The following is a description of a gene set: Genes down-regulated in comparison of macrophages cultured with M-CSF versus macrophages cultured with M-CSF, IFNG and Pam3Cyc. species: Homo sapiens Gene expression analysis of freshly isolated CD14+ human monocytes and monocytes cultured in the presence or absence of interferon (IFN) -gamma for 24 h and then stimulated with Pam3Cys, a Toll-like receptor (TLR) 2 ligand, for 6 h. Results provide insight into mechanisms by which IFN-gamma reprograms early macrophage differentiation and subsequent response to TLR ligands. from publication Hu X, Chung AY, Wu I, Foldi J, Chen J, Ji JD, Tateya T, Kang YJ, Han J, Gessler M, Kageyama R, Ivashkiv LB (PMID 18976936) Human Gene Set: GSE11864_CSF1_VS_CSF1_IFNG_PAM3CYS_IN_MAC_DN, and this is the list of marker genes: VWA7, TBC1D1, ZSWIM8, MICA, PLEKHG1, YKT6, PNPLA5, MAP1S, COQ7, BNIP1, FEZ1, CNIH4, RTP3, LRTOMT, TARP (NCBI Gene Id 445347), VPS13A-AS1, LINC02003, CKAP4, AADACL2, MRPL14, LINC01127, SLC25A32, JAK2, ADGRL3, TSR1, MDM1, PTGER2, CYP1A1, FMO6P, FBXL19, MTHFS, ANKRD18A, RETNLB, DUSP11, SERPINE1, BZW1, BOD1, RBM14, TBK1, IFRD2, GZMB, SLC1A4, BATF3, DSCAM-AS1, STYXL2, EDF1, TMEM11, ZNRF2, ZCWPW1, NBN, GUCD1, ZNF584, TMEM235, DLAT, SLC2A3, AXIN2, ADAM17, SCAF4, LYN, CCT3, FCAR, EIF2AK3, NXNL1, TJAP1, NR4A3, LILRB3, ARL8B, DHCR7, SERF1A, DBI, USP16, TUBB, TRIM13, LINC01845, TBPL1, TRIM26, PTGIR, FPGS, CCRL2, ATG3 (NCBI Gene Id 64422, autophagy related 3), TGM2, EML4, KNG1 (NCBI Gene Id 589), SPATS1 (NCBI Gene Id 221409), ATP11A-AS1, CGA, XPO5, PYCR2, DNAJB5, TMEM165, LRRFIP2, RPF2, SAMD8, NAA11, DGKG, MAPK8, EIF4H, TEX10, SLC4A4, BUD31, NOP58, SIPA1L1, CSF1, SPATA3-AS1, UBE2A, ACSL5, SFTA3, BIN3, GADD45B, PSMB4, CCDC134, KTI12, NXT2 (nuclear transport factor 2 like export factor 2), PDE7A, R3HCC1L, CYTH2, PRKCD, MED1, GLA, MRPL52, FBXO46, URB2, SLC5A6, SECISBP2, STARD3NL, MFSD12, DHCR24, MAP1LC3A, CSRP2, ICAM2, RBM11, ADGRF2P, DYRK3, PCBD1, CLIC1, CDH13, FAM81A, ERLEC1, WDR4, STK40, DSE, HIVEP3, GRID2, EIF4A1, GSTO1, JOSD1, PANX1, ZC3H12C, SPRYD3, LRAT, COX17 (NCBI Gene Id 10063), TYMP, PRKY, ARHGAP25, HLX, RAB21, PPP1R11, ACSL4, XIRP1, UST (NCBI Gene Id 10090), KIAA0040, BOD1L2, C6orf58, TRMT44, NANS, GMPPA, IGFBP4, TEX14, MMAB, UTP11, RHBDD2, PIR, CYP4F12, C16orf46, DGKH, PITPNB, RHOH, MACO1, RIOK1, MFAP1, GPR84, SELENOK, CEBPG, SRPRB, PSMB5, UQCC4, AARS1, SUGP2, SLC36A4, LYSMD2, PTPN7, MRPL27, EXOSC6, C19orf12, USP14, MTHFD1L, MIR9-1HG, RAD54L2